Given this list of marker genes PIK3CA, CNTRL, CEP43, GRB2, STAT3, CUX1, MYO18A, PIK3R1, ZMYM2, TRIM24 (NCBI Gene Id 8805), FGFR1OP2, LRRFIP1, CPSF6, STAT1, STAT5A, BCR, STAT5B, GAB2, here is a description of the gene set: species: Homo sapiens Signaling by cytosolic FGFR1 fusion mutants Human Gene Set: REACTOME_SIGNALING_BY_CYTOSOLIC_FGFR1_FUSION_MUTANTS